Given this list of marker genes Nrg3, Erbb4, Btc, Erbb2, Grb2, Hras, here is a description of the gene set: This event has been computationally inferred from an event that has been demonstrated in another species.<p>The inference is based on the homology mapping from PANTHER. Briefly, reactions for which all involved PhysicalEntities (in input, output and catalyst) have a mapped orthologue/paralogue (for complexes at least 75% of components must have a mapping) are inferred to the other species. species: Mus musculus part of: Signaling by ERBB2 Reactome Pathway: GRB2 events in ERBB2 signaling electronically inferred by orthology from the curated human pathway